Given this list of marker genes Susd5, Trex2, Ptprf, Cux2, Dpys, Traf5, Cidea (NCBI Gene Id 12683), Slc22a15, Ccdc89, Mrps11, Rhox12, Slitrk3, Dazap2, Tmem150b, Osbpl6, Phf8, Dcaf11, Ptchd1, Enox2, Senp3, here is a description of the gene set: from publication Chen Y, Wang X (PMID 31504780) Mouse Gene Set: MIR_7679_3P species: Mus musculus Genes predicted to be targets of miRBase v22 microRNA mmu_miR_7679_3p in miRDB v6.0 with MirTarget v4 prediction scores > 80 (high confidence targets).